Given this list of marker genes SP110, LASP1, UBE2J1, CNPPD1, REEP5, HSD11B1, ARAF, C9orf72, RBM5, TRIOBP, MDP1, SMARCA2, SEPTIN9, SYNJ1, LRIG1, GSTA3, C3orf80, TOB1, EVI5L, PARP9, ABCB9, SF3B1, MARVELD1, S100A13, DOLPP1, ADGRF1, ATXN7L3, ZNF287, UBXN11, TUT4, IRF2BPL, ZMYM5, FBRS, ARF5, CRIPTO, AKT3, PVALB, CHST10, KLHL4, RAB4B, SIDT1, MMP16, ZNF513, PARP3, TBL1X, DIP2B, ENO3, STAT2, FYCO1, MAPK7, ARHGEF6, HERC6, CAMK1D, CHD3, SLC37A3, DDX3Y, MKNK2, JAK2, FAM117B, GSAP, RAP2B (RAP2B, member of RAS oncogene family), RBL2, RHOF, RPE65, ABTB2, FKBP1A, PTPRC, KMT5B, TIMP2, RALGAPB (Ral GTPase activating protein non-catalytic subunit beta), MTMR3, STX16, CYP2D6, MFHAS1, C2orf68, FAAP20, B4GALNT1, BNIP3L, RERE (arginine-glutamic acid dipeptide repeats), RPH3AL, OXT, PEA15, DIO3OS, NEAT1, PTK2B, LBH, RAP2A, MUS81, ANKRD37, LYSMD3, CERS5, S1PR4, TNIP1, MAP3K14, SLC41A1, BIRC2, ATG9A, NUP210, SDHAF1, ZNF281, CLCN4, RASA2, RARG, GMIP, SECISBP2L, PTPN6, MAPKAPK3 (NCBI Gene Id 7867), ASB2, FOXJ2, RFX3 (NCBI Gene Id 5991), RNF114, TMEM106B, WDR26, BFAR, CYTH1, IDNK, GTPBP2 (NCBI Gene Id 54676), SLC28A2, CDIPT, ANXA6, MTERF3, ADCY6, TBX6, ETV3, C12orf57, IRF1, NR4A2, MLLT6, XPO6, HECTD2, LDB1, TMEM64, MADD, TXNDC16, MYD88, PRKD2, SIRT7, RAPH1, PHF1, TRAF3, CCDC88C, MAP4K5, OAS3 (2'-5'-oligoadenylate synthetase 3), DAAM1, DOCK4, PIK3R3, MGST2, MFSD8, ATP6V0E2, CREBBP, ZNF597, JARID2, SLC26A6, TNFSF8, RTN4RL1, GGT1, BACH2, EXTL3, GABRR2, ZNF623, TAP1, UCKL1, YPEL5, KLHDC8B, RUNDC1, JUP, KLHL18, SETDB2, TRIM26, NCOA3, IFNAR1, MAP4K3, TNIP2, CRLF3, ARID5B, XKRX, SLC25A40, CORO1A, STK24, NFAT5, ARAP2, SBK1, CYRIA, DUSP1, FEZ2, SLX4, LYPLA2, MOB3A, TRIP11, NCMAP, HCST, SETD5, SLC17A9, ZHX2, TTC38 (tetratricopeptide repeat domain 38), TNFRSF1A, ATP1B1, WBP1L, RELB, TMEM50A, here is a description of the gene set: Human Gene Set: GSE31082_DN_VS_CD4_SP_THYMOCYTE_DN species: Homo sapiens Genes down-regulated in comparison of CD4- CD8- thymocytes versus CD4+ CD8- thymocytes. from publication Egawa T, Littman DR (PMID 21873191) Mouse thymocytes can be classified into four major subsets based on expression of CD4 and CD8 co-receptors. CD4-CD8- (double negative, DN) cells become CD4+CD8+ (double positive, DP) cells following productive T cell receptor (TCR) beta chain rearrangement. A small proportion of DP cells are selected through interaction of clonal TCRalpha/beta and MHC self peptide complex expressed on thymic stromal cells. DP cell expressing MHC class I-restricted TCR become CD4-CD8+ cells, which will finally differentiate into cytotoxic T cells, while MHC class II restricted selection generates CD4+CD8- helper lineage T cells. We used microarrays to identify genes important for thymocyte differentiation and lineage determination by profiling gene expression in different thymocyte subsets.